The following is a description of a gene set: studied in species Homo sapiens The transcription cycle is divided in three major phases: initiation, elongation, and termination. Transcription initiation include promoter DNA binding, DNA melting, and initial synthesis of short RNA transcripts. Many changes must occur to the RNA polymerase II (pol II) transcription complex as it makes the transition from initiation into transcript elongation. During this intermediate phase of transcription, contact with initiation factors is lost and stable association with the nascent transcript is established. These changes collectively comprise promoter clearance. Reactome Pathway: RNA Polymerase II Transcription Initiation And Promoter Clearance part of: RNA Polymerase II Transcription, and this is the list of marker genes: POLR2D, CDK7, TAF7, TAF8, POLR2I, GTF2A2, GTF2B, TAF12, TAF2, GTF2A1, TAF11, GTF2H5, GTF2H2, TAF4, CCNH (NCBI Gene Id 902), TAF7L, GTF2H1, MNAT1, POLR2C, ERCC2, POLR2G, TAF9, POLR2E, GTF2H3, GTF2F1, TAF13, TAF6, GTF2E1, POLR2K, TAF4B, TAF9B, ERCC3, GTF2E2 (general transcription factor IIE subunit 2), POLR2L, TAF5, POLR2F, TBP, TAF15, POLR2H, POLR2J, GTF2H4, POLR2B, GTF2F2, TAF1L, TAF1, TAF3, POLR2A, TAF10